Given this list of marker genes SLC28A2, RRM2B, CDA, SLC28A3, NT5C1B, RRM2, NT5C1A, SLC28A1, DCK, NT5C, RRM1, SLC29A2, SLC29A1, NT5C2, CMPK1, DCTD, NT5C3A, here is a description of the gene set: studied in species Homo sapiens Two cytidine analogues, gemcitabine (dFdC) and 1-beta-d-arabinofuranosylcytosine (AraC), show significant therapeutic effect in a variety of cancers. However, response to these drugs varies widely. Evidence from tumor biopsy samples shows that expression levels for genes involved in the cytidine transport, metabolism, and bioactivation pathway contribute to this variation in response. In the present study, we set out to test the hypothesis that variation in gene expression both within and outside of this pathway might influence sensitivity to gemcitabine and AraC. Specifically, Affymetrix U133 Plus 2.0 GeneChip and cytotoxicity assays were performed to obtain basal mRNA expression and IC(50) values for both drugs in 197 ethnically defined Human Variation Panel lymphoblastoid cell lines. Genes with a high degree of association with IC(50) values were involved mainly in cell death, cancer, cell cycle, and nucleic acid metabolism pathways. We validated selected significant genes by performing real-time quantitative reverse transcription-PCR and selected two representative candidates, NT5C3 (within the pathway) and FKBP5 (outside of the pathway), for functional validation. Those studies showed that down-regulation of NT5C3 and FKBP5 altered tumor cell sensitivity to both drugs. Our results suggest that cell-based model system studies, when combined with complementary functional characterization, may help to identify biomarkers for response to chemotherapy with these cytidine analogues. from publication Li L, Fridley B, Kalari K, Jenkins G, Batzler A, Safgren S, Hildebrandt M, Ames M, Schaid D, Wang L (PMID 18757419) The 'cytidine analog pathway': genes involved in transport and metabolism of the anti-cancer analogs of cytidine: gemcitabine and cytarabine. Human Gene Set: LI_CYTIDINE_ANALOG_PATHWAY